The following is a description of a gene set: Mouse Gene Set: GOBP_CELLULAR_RESPONSE_TO_ESTROGEN_STIMULUS Any process that results in a change in state or activity of a cell (in terms of movement, secretion, enzyme production, gene expression, etc.) as a result of stimulus by an estrogen, C18 steroid hormones that can stimulate the development of female sexual characteristics. species: Mus musculus, and this is the list of marker genes: Mir125b-1, Mir486, Mir143, Sfr1, Wbp2, Mir142, Mir18, Mir146, Mir195a, Ocstamp, Mir672, Naip1, Cldn18, Mdm2, Mir574, Naip2, Bcas3, Sra1, Mir206, Pelp1, Mir223, Mir493, Mirlet7e, Esr1, Arid5a, Mir708, Trim24, Mir125a, Rara, Ar, Mir451a, Mir126a, Mir466, Mir297-1, Mir207, Sfrp1, Naip6, Mir148a, Crhbp, Mir145a